The following is a description of a gene set: We investigated at which stage of maturation commitment to a stable Foxp3-expressing phenotype takes place. We assessed stability of Foxp3 expression in thymic Foxp3+ Treg subsets of different maturity, defined by CD24 expression. Next we compared gene expression profiles of Foxp3+ Treg subsets (+) of different maturity (24lo, 24int, 24hi) and could identify a set of genes that were specifically up or downregulated in Foxp3+ Tregs, but not in Foxp3- conventional T cells, in a maturation-dependent manner. from publication Toker A, Engelbert D, Garg G, Polansky JK, Floess S, Miyao T, Baron U, Düber S, Geffers R, Giehr P, Schallenberg S, Kretschmer K, Olek S, Walter J, Weiss S, Hori S, Hamann A, Huehn J (PMID 23420886) studied in species Homo sapiens Human Gene Set: GSE42021_CD24LO_TREG_VS_CD24LO_TCONV_THYMUS_UP Genes up-regulated in CD42 low cells from thymus: T reg versus T conv., and this is the list of marker genes: PTH, CHMP4B, FEZ2, PROCR, SLCO3A1, TNFAIP8, ACY1 (NCBI Gene Id 95), FGF3, PDE8A, AP3S2, LCN2, ZRSR2 (zinc finger CCCH-type, RNA binding motif and serine/arginine rich 2), CDKN2AIPNL, XRCC5, RAB10, NAB2, MRPL36, PITPNC1, HOMER3, HLA-DRB1, RHOT1, BIRC3, MYOM2, SNRK, POLR1H, RCC1, CLDN11, GP1BA, PTRH2, HNRNPU, SART3, GLO1, RSAD2, CCL4, XRCC1, BCL3, PTTG1IP, JUN, GSTM5, CACYBP, TRIM13, MS4A6A, YTHDC1, LGALS9B, FST, DGUOK, DYNC1H1, PSMD1, LAMTOR2, ERP44, LAT2, FHOD3, UBXN1, GP1BB, SMC2, CDK1, KCNK2, PIM1, LSM4, TRPC5 (NCBI Gene Id 7224), MAPK14, TAF8, MRPS25, CDC123, TNFAIP2, SPARCL1, MAPK7, LAMA5, CPT1A, TAB2, CPEB1, RPS6KA2, FGG, GANAB, MIX23, PPP1CC, XRCC6, MYH4, LAGE3, CD93, LUC7L, UTRN, GMIP, UBLCP1, OR2H1, YWHAQ, LIMK2, CXCR4, AXIN1, CAMK4, PLPBP, PDAP1, ENPP2, IL1A, CLASRP, IMP3, TRAPPC10, SYPL1, MIPOL1, MIF, ACR, ASH1L, NSD1, ATN1, DICER1, IL13, CFAP20, MET, KLHL7, GFER, PALM, TM7SF3, NUDT4, STAM2, TCEAL9, KIF16B, SRCAP, CYB5A, SUN1, DBNDD2, BLZF1, BMP8B, ARF6, AMFR, CINP, TUBGCP4, GABARAPL1, ANXA10, HLA-DQA1, GALNT2, FZD1, SKI, ITFG1, GJC1, POU5F1, GP9, LSS, HCN1, CTSV, RCAN1, LYL1, TAC1 (NCBI Gene Id 6864), JMJD6, AGAP3, TARDBP, HOXB9, AGXT, TENT5C, CYB5R3, TNPO3, WNK1, LASP1, GPSM1, PRXL2A, MMP9, CERK, HMCES, NPPC, SMARCA2, GART, MLF2, TOLLIP, HRH1, TACR1, AGPAT3, FAM8A1, EIF1AX (eukaryotic translation initiation factor 1A X-linked), DBT, CEP350, ELP2, DOK1, ADGRB1, IDS, TIPIN (TIMELESS interacting protein), TNNI1, LTC4S, AK1, FAM3C, S100A11, B3GALT1, VAV1, M6PR, NTSR2, PRG2, CD34, WRN, BANP (NCBI Gene Id 54971), SAP30, MAP4K4, ILK, KCTD20, RFC3, ANGPTL2, AKIRIN1, COL9A2 (NCBI Gene Id 1905), ZNF740, PLAGL1, NUP54, KIN, CLK1